Given this list of marker genes EPHX2, DHCR7, EBP, TMEM86A, EPHX4, LTA4H, AKR7A2, TMEM86B, RNPEP, EPHX3, ALOX12, EPHX1, here is a description of the gene set: studied in species Homo sapiens Human Gene Set: GOMF_HYDROLASE_ACTIVITY_ACTING_ON_ETHER_BONDS Catalysis of the hydrolysis of any ether or thioether bond, -O- or -S- respectively.